The following is a description of a gene set: Long distance growth of a single axon process involved in cellular development. Human Gene Set: GOBP_AXON_EXTENSION species: Homo sapiens, and this is the list of marker genes: KIAA0319, SEMA6C, BMPR2, SEMA6D, ABL1, L1CAM, WNT3A, SEMA5B, NLGN3, TRIM46, LHX2, TTL, RTN4, DVL1, BARHL2, MAG, SHTN1, SLIT1, DISC1, MAP3K13 (mitogen-activated protein kinase kinase kinase 13), MT3, PAFAH1B1, DSCAM, TNR, RNF6, DIP2B, ADCY10, EDN2, PAK1, RUFY3, FN1, LIMK1, NTRK3, SEMA7A, SEMA3G, ISLR2, TRPV2, CDKL3, TWF2, MAP2, ZFYVE27, SEMA3F, EDNRA, SMURF1, OLFM1, NRP2, CYFIP1, TRPC5, MAP1B, SEMA5A, POU4F3, CLASP2, ADNP, RAPH1, SRF, NRCAM, POU4F2, RTN4R, TNFRSF12A, BCL11A, RYK, ALCAM, CTTN, PLXNA3, C9orf72, CDK5, DNM2, RAB21, EDN3, NTN1, PLXNA4, SPG11, DRAXIN, AUTS2, CXCL12, VEGFA, WNT3, NGF, IFRD1, EDN1, MACF1, NKX6-1 (NK6 homeobox 1), PPP3CB, VCL, CDH4, DCLK1, ULK2, USP9X, GDI1, SSNA1, PTPRS, APOE, SLIT2, SIN3A, ARHGAP4, MEGF8, GOLGA4, HDAC6, SLC9A6, CDKL5, GSK3B, NRP1, SLIT3, SEMA3A, MAPT (NCBI Gene Id 8152), CDH1 (cadherin 1), WNT5A, ANAPC2, ULK1, SEMA4F, LAMB2, ITGB1, NDN